Given this list of marker genes HNMT, PNMT, MAT1A, COMT, MAT2B, MAT2A, INMT, TPMT, NNMT, here is a description of the gene set: Methylation pathways Human Gene Set: WP_METHYLATION_PATHWAYS species: Homo sapiens